The following is a description of a gene set: Any process that stops, prevents, or reduces the frequency, rate or extent of dendrite development. studied in species Mus musculus Mouse Gene Set: GOBP_NEGATIVE_REGULATION_OF_DENDRITE_DEVELOPMENT, and this is the list of marker genes: Mgarp, Bcl11a, Zfp296, Ptprz1, Arf6, Gsk3a, Gsk3b, Fat3, Cyth2, D130043K22Rik, Carm1